Given this list of marker genes Mir133b (NCBI Gene Id 723817), Ednrb, Bcl11a, Tbx6, Dleu2, Nox1, Gsk3b, here is a description of the gene set: Any process that stops, prevents, or reduces the frequency, rate or extent of neuron maturation. Mouse Gene Set: GOBP_NEGATIVE_REGULATION_OF_NEURON_MATURATION studied in species Mus musculus